Given this list of marker genes Stau1, Esrrg, Copb2, Tmem131, Arhgap24, Cdyl, Cks1brt, Tmpo, Astl, Hebp2 (NCBI Gene Id 56016), Ikbkb (NCBI Gene Id 16150), Itgb8, Plxnc1, Smlr1, Gemin7, Synb, Cks1b, Myt1l, Treml2, Dhodh, Spred1, Adam9 (ADAM metallopeptidase domain 9), Taf9b, Rspo4, Itpkb, Serpinb10, Fn3krp, H2al1a, Acap2, Pdcl, here is a description of the gene set: species: Mus musculus from publication Chen Y, Wang X (PMID 31504780) Genes predicted to be targets of miRBase v22 microRNA mmu_miR_344_3p, mmu_miR_344c_3p in miRDB v6.0 with MirTarget v4 prediction scores > 80 (high confidence targets). Mouse Gene Set: MIR_344_3P_MIR_344C_3P